Given this list of marker genes P2RY12, IL6R, TSPAN9, LYN, PRKCQ, F2R, PTPRJ (NCBI Gene Id 5795), ACTN1, VCL, BLOC1S3, SH2B3, METAP1, CD40LG, VAV3, LCK, ACTG1 (NCBI Gene Id 71), SYK, TLR4, EMILIN2, HRG, PEAR1, PRKCA (NCBI Gene Id 5578), CD9, PLSCR1, ADRA2C (NCBI Gene Id 152), PRKCD, GP6, MYH9 (NCBI Gene Id 65212), BLOC1S4, CLIC1, SLC6A4, CEACAM1, TMX1, TREML1, ACTB, C1QTNF1, DGKG, TUBB1, PIK3CA, TYRO3, MERTK, TLN1, GP5, CTSG, MYL9, STXBP3, CD40, DGKD, IL6, F11R (F11 receptor), F2RL2, NOS3, MFSD2B, DGKQ, MMRN1, VWF, PLEK, SVEP1, FZD6, ILK, ENTPD1, RAP2B, PTPN6, CSRP1, VAV2, MYL12A (myosin light chain 12A), SAA1, DGKK, APOE, GNAQ, PLA2G4A, DGKA, PDPN, FGB, HTR2A, PIK3CB, COL3A1, GP1BA, UBASH3B, IL6ST, ADRA2B (adrenoceptor alpha 2B), ADGRG1, PRKG1, JAK2, SLC7A11, P2RY1, PDIA2, PDGFA, FCER1G, DGKI, HBB, DGKH, SERPINE2, THBD, PDGFRA, FGG, PPIA (NCBI Gene Id 5478), PDIA3, GP9, RASA3, ADAMTS18, F2RL3, ADAMTS13, ADRA2A, SRF, WNT3A, GNA13, FERMT3, ALOX12, FGA, AXL, VAV1, PIK3CG, GNAS, P2RX1, ENTPD2, COMP, MAPK14, VPS33B, FIBP, F2, GATA1, DGKZ, CELA2A, SRC, DGKE, FLNA, ITGB3, FUNDC2, HSPB1, ITPR3, SELP, EMILIN1, TSPAN32, PDGFB, C1GALT1C1, PLCG2, TEC, GP1BB, STXBP1, DGKB, PF4, here is a description of the gene set: Human Gene Set: GOBP_PLATELET_ACTIVATION studied in species Homo sapiens A series of progressive, overlapping events triggered by exposure of the platelets to subendothelial tissue. These events include shape change, adhesiveness, aggregation, and release reactions. When carried through to completion, these events lead to the formation of a stable hemostatic plug.